Given this list of marker genes SIRT6, USP5, CAMLG, THRAP3, SEC22B, PPARA, INS, DAZ1, ETFBKMT, MIR21, PHF20L1, MAP1A, TRAF2, IER3, SNCA, NOS2, PML, WASHC1, PRKCG, NBAS, DAB2IP, ATP2B4, RBM38, FYN, GDNF, GSK3A, F8A2, FEZ2, PHAX, ZAR1, METTL14, RBM10, MTMR2, USP36, FOXK2, KLHL40, SF3B3, SENP1, DFFA, MAD2L2, CIRBP, EGFR, NQO1, QRICH2, TNF, NCOR1, LARP1, USP8, TRAF5, ARHGAP5-AS1, AZIN2, CYP51A1, ADRA1A, CSDE1, SLIRP, CST3, E2F1, WDR6, TRDMT1, MIR199A1, DFFB, WNT1, PSEN1 (presenilin 1), TTC36, DAZ4, ACACB, BMF, RBM47, PPTC7 (protein phosphatase targeting COQ7), TARDBP, GPLD1, RBX1, POLDIP2, ANGEL2, CIDEA, PTPN3, HCAR2, TMEM132A, ZKSCAN3, SLC7A5, PDCL3, SERPINB12, PHB1 (NCBI Gene Id 5245), TP53, UBQLN4, EIF4ENIF1, SHH, PABPN1L, SRSF1, ALAD, PANO1 (NCBI Gene Id 101927423), SUFU, IREB2, MIR128-1, FUS (NCBI Gene Id 406232), RNF5, MAGEA3, SMAD3, MDM4, DDRGK1, KDM4A, PARN, USP30, SORL1, WNK1, METTL16, MT3, MTM1, CPTP, TSPO, EIF3H, KIF25, FEZ1, HNRNPAB, MET, UPF3A, LEPR, CDK5RAP3, BCL2, TRAF3IP2, FBP1, STAT3, PPP1R3B, RYBP, MARCHF7, NUPR1, FMC1, NOCT, MAD2L1, USP14, DAPL1, CTSA, NAF1, RRAGA, SNX12, N4BP1, IGF2BP3, USP26, DHX34, RRAGC, STK38L, BOLL, SVIP, OPHN1, TREM2, FBXL4, ATP13A2, CSNK2A2, LRPPRC, DHX36, TENT4B, MTMR8, PIN1, BAG5, PLIN5, SNRNP70, GIPC1, GOLGA2, SECISBP2, MTMR9, TRIM40, NICOL1, UBXN2A, SCFD1, ZDHHC7, EP300, USP7 (ubiquitin specific peptidase 7), YBX3, TIRAP, IRAK3, YBX1, MGAT3, RUBCN, DDIT4, SLC11A1, CSNK2A1, ATRAID, HTRA2, WAC, LZTS1, APOC3, NRDE2, NELL1, STYX, CBFA2T3, A1CF, SYNCRIP, MAPKAPK2, PRKACA, GATA4, CIDEC, AKT1, PKP1, SMARCC1, APOBEC1, MEIOC, TENT5B, PINK1, ARID5A, DHX9, DND1, ELAVL1, TENT2, RBM24, HSP90AB1, TAB3, HNRNPD, RASIP1, FAM76B, IL10RA, EIF4G1, RPL5, LAPTM4B, ZCCHC17, NRBP2, SLC4A1, TAB2, EHMT2, HMGCR, SERPINE2, ALK, TOB1, RELA, USP25, HNRNPA0, DAZL, RNH1, PRMT6, LRRK2, MAPK14, RIC1, TLK2, HCAR1 (NCBI Gene Id 94013), TIMP3, IL10, F8A3, USP9X, METTL1, TENT5C, VIP, SMAD4, SIRT2, FURIN, BSCL2, NSUN2, CDKN2A (cyclin dependent kinase inhibitor 2A), UCHL5, HIPK2, PTPN22, NMNAT1 (nicotinamide nucleotide adenylyltransferase 1), PKP3, GRIN2C, FLCN, ZC3H14, SGTA, RPS7, PIK3CA, TSC1, CLEC16A, EIF4E (NCBI Gene Id 1977), TIMP4, PHF23, HNRNPU, F8A1, MTCH2, TAF15, HNRNPC, HFE, AZIN1, DAP, ADORA1, DAZ3, MCL1, DKC1, LRIG2, CCAR2, MAGEA6, QKI, TSC2, GABARAPL2, RPTOR, LEP, TIMP1, ENDOU, FOXK1, LAMP3, USP38, UBXN1, ANXA2, SMCR8, RRAGD, PAIP1, LARP4B, PBK, MYD88, MLST8, IL1B, MTOR, PFKFB1, HMOX1, ROCK1, TENT5A, GIT1 (GIT ArfGAP 1), TAF1, ZFP36, TENT4A, RILP, MFSD2A, PIK3CG, MYCBP2, RPL23, CRTC3, CSNK2B, VHL (NCBI Gene Id 8056), TRIM27, HDAC6, PSMF1, BECN1, FBLL1, AQP11, TIMP2, TAF9, NOP53, PDE3B, SNX3, APOC1, TMEM39A, RPL11, LYPLA1, FMN2 (formin 2), OGT, GRIN2A, QSOX1, APOA2, RRAGB, DEDD, FXR1, ADRA2A, BAG6, RBM46, HGF, TBC1D14, LARP1B, ACTN3, ADGRB1, TENT5D, RNF41, VPS13C, PSME3IP1, PPP2CA, EIF4G2 (eukaryotic translation initiation factor 4 gamma 2), DAZ2, PARK7, IKBKE, HP, TRIM39, HDAC4, IGF2BP2, EIF4G3, TRIM63, ELAVL4, AXIN2, VPS35 (NCBI Gene Id 91808), TIGAR, FLNA, IGF2BP1, BCL2L1, NPC1, PRKAA1, AGAP2, RGP1, FHIT (fragile histidine triad diadenosine triphosphatase), HERC1, KLHL22, PABPC1, ERFE, here is a description of the gene set: Human Gene Set: GOBP_NEGATIVE_REGULATION_OF_CATABOLIC_PROCESS studied in species Homo sapiens Any process that stops, prevents, or reduces the frequency, rate or extent of the chemical reactions and pathways resulting in the breakdown of substances.